Given this list of marker genes EFL1, SBDS, FIBP, PPIL1, CDC40, DNAJC21, LRBA, CXCR2, SLC37A4, here is a description of the gene set: Human Gene Set: HP_PERSISTENTLY_DECREASED_TOTAL_NEUTROPHIL_COUNT Persistently decreased total neutrophil count Abnormal decrease of the absolute number of neutrophils in the blood, per microlitre, compared to a reference range for a given sex and age-group, which persists for 3 or more months. studied in species Homo sapiens